Given this list of marker genes PDGFB, BMP4, OSR1, TGFB2, ACTA2, NOTCH1, GPR4, SPI1, CD34, WNT4, EPHA2, FOXC2, here is a description of the gene set: The process in which a relatively unspecialized cell acquires the specialized features of a pericyte cell. species: Homo sapiens Human Gene Set: GOBP_PERICYTE_CELL_DIFFERENTIATION